The following is a description of a gene set: from publication Chen Y, Wang X (PMID 31504780) Mouse Gene Set: MIR_7B_5P Genes predicted to be targets of miRBase v22 microRNA mmu_miR_7b_5p in miRDB v6.0 with MirTarget v4 prediction scores > 80 (high confidence targets). studied in species Mus musculus, and this is the list of marker genes: H2-Ob, Rab5if, Cadm3, Smarcd1, Plekho2, Nr4a3, Zkscan8, Ogt, Nrep, Kif16b, Parp1, Gal3st3, Edar, Pde4a, Cntnap1, Rsbn1, Herpud2, Acsl4, Tmem88b, Ipo11, Ddit4, Susd6, Faim2, Lzts3, Pom121l2, Ide, Rhbdd1, Pcnx2, Gtf2a1, Fam168b, Stxbp6, Slc39a1, Chsy3, Mknk1 (NCBI Gene Id 80631), Cct4, Nxnl1, Slc6a9, Spty2d1, Arih1, Calu, Zfp248, Tmco4, Zc3h4, Slc25a25, Tmeff2, Rgs8, Fbln7, Nipal4, Ublcp1, Arid4a, Kcna1, Sp1, Faxc, Mapk4, Ctsb, Rras2, Sh3glb1, Dgki, Mapk12, Srf, Hhip, 9930012K11Rik, Zfp93, Serf2, Ghitm, Rb1, Rgs7bp, Marf1, Megf9, Lsm11, Raf1, Kdm3b, Snca, Slc17a1, Ttc14, Kmt5a, Rsbn1l, Hcn1, Adamts8, Pgam5, Vps26a, Cat, Crebrf, Dkk3, Ssbp2, Pfn2, Kif13a, Zbtb22, Adgrl2, Xcr1, Ankrd12, Atp10a, Bloc1s4, Kcnf1, Ccdc120, Vdac3, Crls1, Anapc11, Usp40, Bcorl1, Nr1h2, Fam53c (NCBI Gene Id 66306), Asxl1 (ASXL transcriptional regulator 1), Atg3, Mlh3, Aplp2, Jade1, Zbtb4, Pilra, Tnrc6a, Pan2, Prkcb, Pole4, Mecp2, B3gnt6, Tbx20, Cby2, Socs2, Tex261, Vdac1, Slc16a9, Plec, Clasp2, Ggt7, Bpifa1, Pik3cd, Bicdl2, Mobp, Cdon, Ube2q2l (NCBI Gene Id 100502936), Iglon5, Tmem230, Rnf141, Fbxw2, Psme3, Smg1, Aars2, Med19, Elmo1, Azgp1, Wfdc1, Pbx3, Tcf12, Trp53inp2, Nemp1, Ermap, Ints10, Spopfm2 (speckle-type BTB/POZ protein family member 2), Ambra1, Ezh1, Rps6kb1, Ptrhd1, Champ1, Mcc, Smim12 (NCBI Gene Id 80284), Hdlbp, Xpo7, Mtmr1, Casp9, Rnf41, Gmeb1, Oxr1, Smyd5, Fbxo28, Gjc1, Ids, Eif4ebp2, Plxna1, Klf12, Draxin, Itch, Atxn7, Elfn2, Adgre4, Nr2c1, Hecw1, Zfp609 (NCBI Gene Id 214812), Fndc4, Itga4 (integrin alpha 4), Cnppd1, Fam131b, Gkn1, Rnf144a, Fam168a, Spata2, Mapkap1, Adcy9, Plp2, Jade3, Mafk, Dach1, Zc4h2, Wdr47, Ints7, Dnajc5, Osbpl11, Me3, Slc4a7, Ckap4, Slc25a23, Dync1li2, Esr2, Atf7, Sting1, Ltn1, Traf5, Wipf2, Tmf1, Satb1, Klf4, Zfp287, Tmed9, Cnnm4, Zfp85, Pygo2, Slc38a2, Strn3, Slc22a23, Pdha1 (pyruvate dehydrogenase E1 alpha 1), Nfic, Chd3, Gdpd4, Ptgfrn, Snhg11, Rfx2, Stard13, Vma21, Frrs1l, Atp2b2 (ATPase, Ca++ transporting, plasma membrane 2)